Given this list of marker genes AP5Z1, AP4E1, UBAP1, SELENOI, CPT1C, NFU1, PGAP1, ARSI (arylsulfatase family member I), FLRT1, PNPLA6, AP4S1, IBA57, ATP13A2 (NCBI Gene Id 63919), MT-ATP6, HACE1, KIF1A, KDM5C, FARS2 (phenylalanyl-tRNA synthetase 2, mitochondrial), AP4B1, CCT5, AP4M1, KLC2, SLC33A1, FA2H, ZFR, MARS1, RAB3GAP2, WASHC5, PLP1, KY, KIDINS220, RTN2, KPNA3, here is a description of the gene set: Progressive spastic paraplegia species: Homo sapiens Human Gene Set: HP_PROGRESSIVE_SPASTIC_PARAPLEGIA